Given this list of marker genes Rigi, Rfc3, Ruvbl1, Mcm2, Dhx8, Nav2, Fancm, Top6bl, Ercc6, Recql4, Dna2, Top1mt, Ruvbl2, Mcm8, Pif1, Chd9, Trp53, Ddx51, Upf1, Dhx30, Hells, Smarca1, Helz2, Mcm6, Top2a, Smarca5, Ddx5 (DEAD box helicase 5), Dicer1, Dhx9, Supv3l1, Chd1l, Blm, Chd1, Chd8, Wrnip1, Dhx33, Dhx58, Hfm1, Hltf, Rtel1, Rfc5 (replication factor C (activator 1) 5), Top3b, Ddx41, Rad54l2, Ddx19b, Chd5, Mcm3, Zgrf1, Ddx3x, Mtrex, Eif4a3, Ddx4, Eif4a1, Rad54b, Ddx6, Mcm9, Ighmbp2, Smarca2, Ddx56, Ercc2, Fxr1, Ddx54, Ddx10, Ddx31, D1Pas1, Setx, Spo11, Ddx27, Chd4, Ddx39a, Chtf18, Eif4a3l1, Ercc6l2, Smarca4, Chd7, Dhx35, Ythdc2, Top3a, Mov10, Ddx20, Ercc6l, Znfx1, Xrcc5, Rfc4, Dhx36, Ddx55, Ddx3y, Ddx46, Fmr1, Ddx28, Ddx50, Mov10l1, Ddx19a, Ddx21, Dhx37, Ercc3, Ddx1, Ddx42, Dhx29, Dhx57, Dhx34, Wrn, Eif4h, Helq, Tdrd9, Smarcad1, Dhx38, Ddx49, Fbh1, Brip1, Top2b, Aqr, Mcm5 (minichromosome maintenance complex component 5), Ep400, Snrnp200, Atrx, Rad54l, Dhx16, Chtf8 (CTF8, chromosome transmission fidelity factor 8), Xrcc6, Recql, Dqx1, Smarcal1, Ddx59, Ddx52, Top1, Ifih1, Eif4b, Rad51, Rad50, Recql5, Twnk, Shprh, Ddx47, Chd6, Hnrnpa1, Tdrd12, Dhx15, Sub1, Ttf2, Chd2, Dhx40, Polq, Skic2, Ddx43, Eif4a3l2 (NCBI Gene Id 434080), Mre11a, Ddx18, Dhx32, Ascc3, Ddx17, Mcm4, Helz, Eif4a2, Gtf2f2, G3bp1, Anxa1, Mcm7, Dscc1, Zranb3, Ddx25, Helb, Ddx24, Ddx11, Ddx39b, Rfc2, here is a description of the gene set: Catalysis of a reaction that alters the conformation of a nucleic acid. species: Mus musculus Mouse Gene Set: GOMF_NUCLEIC_ACID_CONFORMATION_ISOMERASE_ACTIVITY